Given this list of marker genes Gata4, Trpc3, Nfatc3, Inpp5f, Gata6, Chaer1, Hey2, Ezh2, Nppb, Klf15, Kdm4a, Bmp10, Ppp3ca, Camta2, Bmp4, Mlip, Myh6, Smad1 (SMAD family member 1), Atp2b4, Smad4, Nppa, Pparg, Myh7, Mir208b, Errfi1, Bmp2, Foxo1, Mef2c, Atp2a2, Oga, Lmna, Smad3, Tcap, Acacb, here is a description of the gene set: studied in species Mus musculus The process in which cardiac muscle adapts, with consequent modifications to structural and/or functional phenotypes, in response to a stimulus. Stimuli include contractile activity, loading conditions, substrate supply, and environmental factors. Mouse Gene Set: GOBP_CARDIAC_MUSCLE_ADAPTATION